Given this list of marker genes NPR2, HOXA3, SEMA3C, CEACAM1, ACVRL1, DLL4, NPR3, EPAS1, ATG5, ENSG00000274276, MIR20A, EXT1, TGFB1, FOXC2, NOL3, CRB1, FLT4, MIR27B, NDP, BCR, IGF1, JAG1, FGF8, AGTR2, EDNRA, BMPR2, TGFB2 (NCBI Gene Id 7042), MDM2, BAK1, CST3, FOXC1, NPPC, MEF2C, MIR143, MIR17, RBPJ, TMBIM1, RSPO3, BAX, CCR2, ACE, MIR29B1, CHD7, CBS, AXL, ATP7A, LIF, NOS3, ACVR2B, BGN, AGT, HRG, DBH, FGF10, here is a description of the gene set: Human Gene Set: GOBP_BLOOD_VESSEL_REMODELING The reorganization or renovation of existing blood vessels. studied in species Homo sapiens